Given this list of marker genes Abcb4, Xrcc4, Tmem30a, Atp8a2, Fasl, Atp8a1, here is a description of the gene set: studied in species Mus musculus Mouse Gene Set: GOBP_REGULATION_OF_PHOSPHOLIPID_TRANSLOCATION Any process that modulates the frequency, rate or extent of the translocation, or flipping, of phospholipid molecules from one monolayer of a membrane bilayer to the opposite monolayer.